Given this list of marker genes NFKBIA, PTPN6, STXBP2, MEFV, UNC13D, STX11, PRF1, here is a description of the gene set: species: Homo sapiens Human Gene Set: HP_ABNORMALITY_OF_CYTOKINE_SECRETION Abnormality of cytokine secretion An abnormality in the production or cellular release of a cytokine (i.e., any of the non-antibody proteins made by inflammatory leukocytes and some non-leukocytic cells that affect the behavior of other cells).